The following is a description of a gene set: Pan-Hdac inhibitors (HDACi) are endowed with a potent anti-inflammatory activity, but the relative role of each of the eleven Hdac proteins sensitive to HDACi to the inflammatory gene expression program is unknown. Using an integrated genomic approach we found that Hdac3-deficient macrophages are unable to activate almost half of the inflammatory gene expression program when stimulated with lipopolysaccharide (LPS). A large part of the activation defect is due to loss of basal and LPS-inducible expression of IFNb, which in basal cells maintains Stat1 protein levels, and after stimulation acts in an autocrine/paracrine manner to promote a secondary wave of Stat1-dependent gene expression. We show that loss of Hdac3-mediated repression of nuclear receptors leads to hyperacetylation of thousands of genomic sites and associated gene derepression. The upregulation of the constitutively expressed prostaglandin endoperoxide synthase, Ptgs1 (Cox-1), has a causative role in the phenotype, since its chemical inhibition reverts the Ifnb activation defect. These data may have relevance for the use of selective Hdac inhibitors as anti-inflammatory agents. studied in species Homo sapiens from publication Chen X, Barozzi I, Termanini A, Prosperini E, Recchiuti A, Dalli J, Mietton F, Matteoli G, Hiebert S, Natoli G (PMID 22802645) Genes up-regulated in macrophages with knockout of HDAC3: heterozygous versus homozygous. Human Gene Set: GSE33162_HDAC3_KO_VS_HDAC3_KO_MACROPHAGE_UP, and this is the list of marker genes: GRINA, BST2, PODXL, PARVB, SGSM3, LGALS3BP, CAMSAP1, RBM38, HLA-B, ANKRD40, RNASET2, IFI27L2, CIC, TUBA3C, GPN1, IER3IP1, IL4R, PTOV1, ASS1, ZNHIT3, BNIP1, TOMM34, SIDT1, CYP4A11, OLIG1, AXIN1, PMEPA1, CSRP1, ANKS3 (NCBI Gene Id 124401), B3GALT5, ADAP2, MCOLN3, ISCU, SHMT2, PSME1, TNRC6C, ORC2, OAS3, STAT1, SCYL1, TRAF6, PARP9, SMARCAL1, SRPX, TRAIP (NCBI Gene Id 10293), SUPT6H, TAPBPL, GBP2, HBG2, ATG101, PTGES (NCBI Gene Id 9536), RRP15, ARHGAP20, B2M, CALB2, HLA-C, USP18, BUD31, MAPK8IP1, OLIG3, ZNF574, REG4, TRIR, CDCP1, SLITRK1, ERCC8, MARK2, SGTB, IL13RA2, PCK1, PWP2, ADA, RREB1, PSMB5, ATOH1, TPBG, CDK7, ADPGK, RAB13, IL21R, INPP1, CYB5R1, STUB1, GLE1, GALR1, PTCD2, DDX60 (NCBI Gene Id 55601), CIAO1, MRTFA, CXCL10, TRAPPC14, PPIC, LMNA, SRRT, KRTAP19-3, SPHK2, RPS9, CPXM2, ENDOG (endonuclease G), ZNF764 (NCBI Gene Id 92595), ZMIZ2, PPP1R10, IRF9, BCL9L, STARD3 (NCBI Gene Id 10948), HLA-G, GBP6, GTPBP1, CITED1, ERBB3 (erb-b2 receptor tyrosine kinase 3), ATF5, MCM3AP, RTP4, TRAPPC4, ARHGEF12, CRCT1, HOOK2, GNB1L, KEAP1, SCNN1G, EPHA5 (EPH receptor A5), ZDHHC12, ACHE, TRAF4, CLIP1, CA8, LANCL1, TRAFD1, ZNF264, AEN, IL36G, ELAC2 (elaC ribonuclease Z 2), PARP14, NME3, PSMC3, SIGMAR1, TRIM15, CD247, TAP1, LONP1, AIMP2, TAPBP, IQCC, NAA38 (NCBI Gene Id 84316), MOGS, PRDM4, CDH10, ZBTB8A, NUBP1, PPP1R14B, TRAF1, UGT8, PSMG4, OLFML2B, BCL2, SMG6, PLA2G12B, TFIP11, JPT1, TXNDC11, EZH1, RIOX1, GUCY1A1, PLAAT3, EPPIN, TNFAIP2, LIPG, TBX6, CMTR1, PRAMEF2, ECD, POLR2E, FBXW9, RAB40C, TMEM186, KMT2A (lysine methyltransferase 2A), AGRN, PARP12, ATG4D, CCR7 (NCBI Gene Id 1236), TEX13B, CAVIN1, HTT, IFI35, VILL, IFIT3, SRXN1, AK1, CYSLTR2, GPANK1, PRPF6, MUSK, OAS1, SLC22A5, MEPCE, SPOCK3, SCARA3, RNF141, PRPF38A